The following is a description of a gene set: This event has been computationally inferred from an event that has been demonstrated in another species.<p>The inference is based on the homology mapping from PANTHER. Briefly, reactions for which all involved PhysicalEntities (in input, output and catalyst) have a mapped orthologue/paralogue (for complexes at least 75% of components must have a mapping) are inferred to the other species. Reactome Pathway: SUMO is proteolytically processed part of: Processing and activation of SUMO species: Mus musculus electronically inferred by orthology from the curated human pathway, and this is the list of marker genes: Sumo1 (small ubiquitin-like modifier 1), Senp2